Given this list of marker genes Sptlc2, Sptssb, Gm6993 (predicted gene 6993), Ormdl3, Ormdl1 (ORM1-like 1 (S. cerevisiae)), Ormdl2, Sptssa, Sptlc1, Sptlc3, here is a description of the gene set: A protein complex that catalyses the condensation of L-serine with palmitoyl-CoA to form 3-ketosphinganine, the sphingoid base which is the starting point for all sphingolipids. In bacteria the enzyme is a cytoplasmic homodimer, whereas in eukaryotes the enzyme is a multiprotein complex localised to the endoplasmic reticulum. The eukaryotic complex consists of catalytic components (SPTLC1, SPTLC2 and SPTLC3 in humans; LCB1 and LCB2 in S. cerevisiae) and regulatory components, which include activators (SPTSSA/SPTSSB in humans, TSC3 in S. cerevisiae) and negative regulators (ORMDL1/ORMDL2/ORMDL3 in humans, ORM1/2 in S. cerevisiae ). species: Mus musculus Mouse Gene Set: GOCC_SERINE_PALMITOYLTRANSFERASE_COMPLEX